The following is a description of a gene set: Mouse Gene Set: GOMF_CARBOHYDRATE_MONOATOMIC_CATION_SYMPORTER_ACTIVITY Enables the transfer of a solute or solutes from one side of a membrane to the other according to the reaction: sugar(out) + cation(out) = sugar(in) + cation(in). studied in species Mus musculus, and this is the list of marker genes: Slc5a10, Slc5a2, Slc45a3, Slc5a9, Slc5a1, Slc45a1, Slc23a2, Slc23a1, Slc5a4a, Slc45a2, Slc5a3, Slc5a11, Slc5a4b, Gm5134, Slc45a4, Slc2a4